Given this list of marker genes CEP85L, TUBB3 (tubulin beta 3 class III), MACF1, PI4K2A, ZEB2, ACBD6, DCC, RERE, here is a description of the gene set: An anomaly of the anterior commissure, a bundle of nerve fibers that connect the two cerebral hemispheres across the midline. The anterior commissure plays a role in pain sensation and contains decussating fibers from the olfactory tracts. Human Gene Set: HP_ABNORMALITY_OF_THE_ANTERIOR_COMMISSURE Abnormality of the anterior commissure species: Homo sapiens